Given this list of marker genes POP7 (POP7 homolog, ribonuclease P/MRP subunit), TEX2, NEUROG1, SNIP1, ABCC5, YY1, BTG1, PHACTR2, IRF1, TET3, TOGARAM1, TAFA1, HECA, SKIDA1, KLF7, EMX2, SPOCK1, RNF216, NRBF2, ACBD5, ABCB7, ROBO2, DGKE, PTPRG, BMP3, SHANK2, ARHGAP21, MID1IP1, WDR33, PDZD11, WDFY3, PHF12, ST8SIA5, MAF, CLIP1, LY75, MFSD6, STIM2, CLTC, TES, FRZB, ARAP2, PHF14, TRPC3 (transient receptor potential cation channel subfamily C member 3), USP28, MB21D2, LPGAT1, MBD2, ITPR1, PCNX1, NHLH2, PTPN4, RRAGD, SCUBE3, EIF4E2, JARID2, CENPO, R3HDM1, SLAIN1, PPP6R2, MBNL3, CBX6, PMEPA1, ST18, DCUN1D3, MECP2, RBM25, MIGA1, UBE2D2, PIK3C2A, TSC1, USP33, FASTK, POU4F1, FAT3 (FAT atypical cadherin 3), CUL3, GAREM1, CNOT6, PPFIA2, HS3ST5, CHD5, SBNO1, PPARG, CD2AP, SLC44A1, ZEB2, SIX4, MEMO1, STX6, ABHD3, RPS6KA5, CBY1, EPS15, TSHZ1, NSD3, SECISBP2L, RACGAP1 (Rac GTPase activating protein 1), LDAF1, RO60, INO80, CPEB1, BRWD1, WDR47, ACSL4 (acyl-CoA synthetase long chain family member 4), ZFYVE26, ITGB8, ASXL2, CLCN3, PAN3, SMAP1, KMT2C, RUNX3, UBB, AGFG1, ULK2, THOP1, SPART, PIP4P2, MTMR10, EREG, SPATA2, SNX31, BTBD3, DOCK3, LRP6, FSTL5, PSAP, ZBTB18, WEE1, CLCN5, MET, TMEM50B, RAI2, CNOT7, SAMTOR, MEOX2 (NCBI Gene Id 4223), SYBU, GJA1, CEP170, ANKIB1, ENPP5, BRWD3, TRIM2, MPHOSPH9, BTAF1, LSMEM1, KIAA1191, DSEL, ITPRIPL2, SEL1L3, HECW2, MAP3K20, SYT6, BAHD1, MYBL1, WDR20, HPRT1, AKIRIN2, BTBD7, SLC2A4RG, RFX7, AKAP1, ADAM12, YTHDF2, LCORL, SOCS5, APPL1, HOXA3, RAB5A, KRTAP26-1, ARHGEF4, VPS37A, CASD1, KIF13A, AKAP11, PPP1R15B, ERBIN, NABP1 (nucleic acid binding protein 1), MAP3K12, CCNY, KDM2A, SMOC1, FYN (FYN proto-oncogene, Src family tyrosine kinase), PIKFYVE, SNX5, LRP8, CGGBP1, LDLR, DYNLL2, DDX6 (DEAD-box helicase 6), SRSF2, RBBP8, RAD51B, EDN1, LGALSL, PHF20, POU3F2, PHF3, PTP4A1, LONRF3, IGF1, HOXD1, DNAJC16, DIAPH3, SERINC3, TMEM250, TMOD1, CPEB3, ZBTB20, BMPR2, UBXN2B, CAMSAP2, DLC1, ACBD3, PRKAA1, TENT2, MIGA2 (mitoguardin 2), DENND10, VGLL4, RTCA, SH3D19, FZD6, PDIK1L, BPTF, CALM2, MSMO1, HSPA8, CCDC6, FOSL1 (NCBI Gene Id 8061), ZBTB4 (zinc finger and BTB domain containing 4), IL15, TANC2, SPTY2D1, ARHGEF26, LRIG1, DAAM1, PRKD3, ATG14, LMLN, PLCB1, IMPDH1, LDLRAD4, INSIG1, CYP2U1, WNK1, TBL1XR1, PIGA, CRACD, FIBIN, BTF3L4, TFCP2L1, AGO1, AGO4, PGM2L1, CBLB, G0S2, MACIR, LRP12, NFIB, SFMBT1, ADCY1, NPNT, ARHGAP1, SALL3, THSD7A, PSD, BHLHE41, NACC2, DYNC1LI2, SERBP1, RNF38, JADE1, ING2, CHST1, HCFC2, KCNA4, GTF2H1, ABRAXAS2 (abraxas 2, BRISC complex subunit), PURG, LRRTM2, CYSLTR1, ZNF609, FMR1, ATP6V1B2, HEG1, NFIA, TACC2, MIER1, DENND4C, FERMT2, DCBLD2, ZNF107, VCF1, CDS1 (CDP-diacylglycerol synthase 1), DNAL1, SNX2, LRP2, ERP44, USP13, AAK1, FUT9, DLG5, PHAF1, ARL6IP1, ACSL1, BLCAP, FRMD6, SLC6A6, HIVEP2, DLL1, UBE2W, ZNF800, OTUD3, DPYSL2, DICER1, PRUNE2, ZNF862, DSG1, ZNF217, EOGT, MDM4, FMC1, FSD1L, RNF145, JMY, RTN1, NPEPL1, TLCD3A, SAMD8, CDK19, NCKAP5, EPC2, RAPGEF4, FBXO48, USP8, CSMD1, CCDC126, UBE3B, PEX5L, OSBPL6, SULF1, RAP2C, TGFBR2, GADD45A, CAPRIN2, RAB12, EBF3, ZFYVE9, KBTBD8, CD69, RALGPS2 (Ral GEF with PH domain and SH3 binding motif 2), AR, ATP12A, NECTIN3, ACVR1, APCDD1, PAK6, TGFBR1, VPS13D, G3BP2, BAG5, ERCC4, ZCCHC14, SAR1B, STON2, MTCL1, SBF2, NPAT, CFL2, SMARCD2, RASD1, MFF, UBA3, MDFIC, ZMAT3, SZRD1, DCAF8, MMGT1, ESR1, ATG16L1, EGLN3, SPEN, MBNL1, CBFB, FOXF2, MLLT6, CNOT4, IL1RAP, ARHGAP12, SPHK2, PIK3CB, PLAA, NALF1, ELK3, C2orf15, FBXO28, TNRC6C, SLMAP, SOS2, MAPK1, ZNF594, here is a description of the gene set: Human Gene Set: MIR130A_3P species: Homo sapiens Genes predicted to be targets of miRBase v22 microRNA hsa-miR-130a-3p in miRDB v6.0 with MirTarget v4 prediction scores > 80 (high confidence targets). from publication Chen Y, Wang X (PMID 31504780)